The following is a description of a gene set: The binding of VEGF ligands to VEGFR receptors in the cell membrane induces dimerization and activation of the latter, initiating intracellular signaling cascades that result in proliferation, survival, migration and increased permeability of vascular endothelial cells. The receptors predominantly form homodimers but heterodimers between VEGFR-1 and -2 have been observed. Although both VEGFR-1 and -2 are expressed in the vascular endothelium, the angiogenic activities of VEGFs are transduced mainly through VEGFR-2 in vivo. Reactome Pathway: VEGF binds to VEGFR leading to receptor dimerization part of: VEGF ligand-receptor interactions studied in species Homo sapiens, and this is the list of marker genes: FLT4, VEGFC, KDR, PGF, VEGFD, VEGFB, FLT1, VEGFA